The following is a description of a gene set: studied in species Homo sapiens The RUNX1:CBFB complex regulates transcription of the SPI1 (PU.1) gene, involved in differentiation of hematopoietic stem cells (HSCs). RUNX1 recruits histone methyltransferase KMT2A (MLL) to the SPI1 gene locus, leading to generation of the activating H3K4Me3 mark on nucleosomes associated with the SPI1 promoter and the upstream regulatory element. SPI1 transactivation represses self-renewal and proliferation of HSCs and is needed for commitment of HSCs to specific hematopoietic lineages.<br>As a component of the TAL1 transcription factor complex, involved in acute T cell lymphoblastic leukemia (T-ALL), RUNX1 can promote growth and inhibit apoptosis of hematopoietic stem cells by stimulating transcription of the MYB gene and possibly the TRIB2 gene. part of: Transcriptional regulation by RUNX1 Reactome Pathway: RUNX1 regulates transcription of genes involved in differentiation of HSCs, and this is the list of marker genes: CCNH, H2BC5, PSMA1, H2BC14, H2AC7, H2AC4, PSMA4, PSMC4, UBC, SEM1, PSMD6, H2BC3, PSMD12, ABL1, KMT2A, H2BC17, PSMA7, UBA52, PSMC3, PSMB1, SPI1, PSMB5, ADRM1, H2AB1 (H2A.B variant histone 1), UBB, H2BC4, RUNX1, PSMB2, YAP1, TCF12, H2AX, H2BC15, LMO1, H3C1, PSMC2, H2BC21, PSMC5, H2BC12L, PSMB6, PSMC1, PSMD2, LMO2, PSMB7, GATA3, PSMA3, MNAT1, PSMA2, H2AZ2, PSMD1 (proteasome 26S subunit, non-ATPase 1), RPS27A, H3C15, PSMD8, H2AJ, PSMB4, PSMA5, LDB1, H2AC18 (NCBI Gene Id 8337), PSMD7, GATA2, H2BC12, MYB, H3-3A, TAL1, H4C1, CDK7, H2AC6, ITCH, PSMD14, PSMD11, H2BC11, PSMA6, H2BC13, GATA1, CBFB, PSMB3 (proteasome 20S subunit beta 3), TCF3, PSMD3, H2AC20, H2BC9, PSMC6, PSMD13, H2BC26, TP73, H2BC1, H2AC14